Given this list of marker genes Smo (NCBI Gene Id 319757), Rian, Acta2, Cygb, Akap12, Nr1d1, Il17a, Il17ra, Gsk3b, Fgfr1, Rgcc, Rps6ka1, Lep, Dgat1, Ugt1a1 (UDP glucuronosyltransferase 1 family, polypeptide A1), Ddr2, Myb, Ulk3, Mdm2, Pdgfb, Zeb2, Myocd, Fam114a1, Gclc, Pdgfrb, Gclm (NCBI Gene Id 99692), here is a description of the gene set: Mouse Gene Set: GOBP_FIBROBLAST_ACTIVATION studied in species Mus musculus A change in the morphology or behavior of a fibroblast resulting from exposure to an activating factor such as a cellular or soluble ligand.